Given this list of marker genes AKR7L, HAL, HJV, ESRP2, EDNRB, SLC43A3, TBX15, MT1L, CTPS1, ADAMTSL3, PLEK2, PER3, RHOD, CLYBL (citramalyl-CoA lyase), CYP7B1, AKR7A3, PEMT (NCBI Gene Id 10400), ACSL1, A1BG, TSPYL5, CYP1A1, here is a description of the gene set: studied in species Homo sapiens Genes hypermethylated and downexpressed in hepatoblastoma (HB) tumors as compared with non-tumor (NT) adjacent tissue assessed by Infinium MethylationEPIC 850K array and Human Transcriptome Array 2.0 & RNA-sequencing. Background & Aims: Hepatoblastoma (HB) is a rare disease. Nevertheless, it is the predominant pediatric liver cancer, with limited therapeutic options for patients with aggressive tumors. Herein, we aimed to uncover the mechanisms of HB pathobiology and to identify new biomarkers and therapeutic targets in a move towards precision medicine for patients with advanced HB. from publication Carrillo-Reixach J, Torrens L, Simon-Coma M, Royo L, Domingo-Sàbat M, Abril-Fornaguera J, Akers N, Sala M, Ragull S, Arnal M, Villalmanzo N, Cairo S, Villanueva A, Kappler R, Garrido M, Guerra L, Sábado C, Guillén G, Mallo M, Piñeyro D, Vázquez-Vitali M, Kuchuk O, Mateos ME, Ramírez G, Santamaría ML, Mozo Y, Soriano A, Grotzer M, Branchereau S, de Andoin NG, López-Ibor B, López-Almaraz R, Salinas JA, Torres B, Hernández F, Uriz JJ, Fabre M, Blanco J, Paris C, Bajčiová V, Laureys G, Masnou H, Clos A, Belendez C, Guettier C, Sumoy L, Planas R, Jordà M, Nonell L, Czauderna P, Morland B, Sia D, Losic B, Buendia MA, Sarrias MR, Llovet JM, Armengol C (PMID 32240714) Human Gene Set: CARRILLOREIXACH_HEPATOBLASTOMA_VS_NORMAL_HYPERMETHYLATED_AND_DN